Given this list of marker genes SCAND2P, SERPINH1, HDAC8, ZMYM2, TUBA1C, SPATA12, BRD1 (bromodomain containing 1), ATP5F1B, RAD52, BMP4, ATP8B4, PDLIM7, MEX3D, CCDC102B, F9, TRO, FAM86C1P, CSRP1, DIRAS3 (NCBI Gene Id 9077), STX11, TNRC6B, ZNF692, COX8A, BRWD1, IRAG1-AS1, SCAP, UBE4B, NUBP2, ZDBF2, MIR646HG, RAB3D, LPCAT4, LYPD1, COLGALT1, GCSAM, ZNF25 (zinc finger protein 25), SFXN2 (sideroflexin 2), HPCAL1, TNRC6C, CAVIN1, RNF168, BCL6B, TINAGL1, FLNA, MAGED2, TMEM234, EXOSC5, CBL, RFWD3, RPL10, ISYNA1, TNS2, STXBP5, GPS1, RIC8B, MCAM, ALPK3, ZNF763, PDGFB, INHBA, PDIA4, LINC01020, TUBB3, KIF20B, ZMAT5, HOXA7, KSR1, IFNA21, CYP2B7P, FZD4, ACMSD, ELN, MFN2, EIF4EBP1, IFNA4, ANGPT2, PPM1H, SNAI2, ZNF516, HOXA10, GARIN1A, MALL, SLC9A3-OT1, MAGEL2, RPL8, NAP1L5, DCUN1D2, FSCN1, ALKBH5, ZNF781, ST6GALNAC4, ZNF513, RWDD2A, BAZ2B-AS1, DUSP28, CCNI, RBM48, GPX4, POPDC3, CRYAB, SLC25A4, MBTD1, POMGNT1, MS4A5, TK2, TMEM9, ZYX, CPSF2 (NCBI Gene Id 53981), MLLT1, B9D1, ZNF678, SNRPC, PPIE, RNF19A, MAGEA1, CRIP2, RARB, MPZL3, RABGGTA, PXDC1, ABHD12, NPR2, PROM2 (NCBI Gene Id 200480), MLLT3, ANKRD33B, KPNA6, IFNA17, SND1, AFG2B (AFG2 AAA ATPase homolog B), AAAS, TRIM6, CDC25A, FUT11, RAB5C, RPL29, RPGR, FEM1A, TARS2, ARHGEF37, UNC5CL, WEE2-AS1, MEDAG, NINJ2, ZNF493, PKM, NMUR2, ITGA5, GRN, CLSTN1, CCDC144NL-AS1, LRRC42, KMT5A, PKD1P6, C1GALT1, FBLIM1, PAGR1, POLR1A, LINC00924, TNFSF15, KDM2A, SMAD6, ELF5, PPM1D, TEFM, RAB2A, PSMB5, PRIM2, TLN1, UPF1, ASCC2, ID1, PXN, VCP, DHX35, FAM111B, CKAP2L, SMARCA2, POLR2J2, CPNE1, IGFBP4, MYH9, TMEM198B, BBS1, ITSN1, HSPB1, TNFRSF10D, OLFM4, FSD1L, NAA40, LPP-AS2, CEP68, GCOM1, OSBPL1A, PPP1R14B, here is a description of the gene set: Human Gene Set: GSE43863_NAIVE_VS_TH1_EFF_CD4_TCELL_D6_LCMV_UP CD4 T follicular helper (Tfh) cells provide the required signals to B cells for germinal center reactions that are necessary for longlived antibody responses. However, it remains unclear whether there are CD4+ memory T cells committed to the Tfh lineage after antigen clearance. Using adoptive transfer of antigen-specific memory CD4+ subpopulations (based on CXCR5 and Ly6c expression)in the LCMV infection model, we found that there are distinct memory CD4+ T cell populations with commitment to the Tfh and Th1 lineages. Our conclusions are based on gene expression profiles, epigenetic studies and phenotypic and functional analysis. The gene expression profiles of virus-specific CD4 T cell subets at effector and memory stages is presented here. from publication Hale JS, Youngblood B, Latner DR, Mohammed AU, Ye L, Akondy RS, Wu T, Iyer SS, Ahmed R (PMID 23583644) species: Homo sapiens Genes up-regulated in CD4 SMARTA cells: naïve versus during acute infection of LCMV.